Given this list of marker genes Stra6, Hipk2, Hoxa7, Ndst1, Lrp6, Myo3a, Pitx2, Fgf8, Fzd6, Srf, Dll1, Mmp16, Hoxb7, Slc39a3, Atp8a2, Prox1, Hlx, Nckap1, Ovol2, Bloc1s5, Tbx3, Myf5, Shh, Chst11, Triobp, Grhl2, Osr2, Mir96, Wdpcp, Tifab, Mapk3, Col11a1, Kdm2b, Eif4a3l2, Eif4a3l1, Foxf2, Eya1, Sox9, Mthfd1l, Clrn1, Tgfbr2, Tshr, Efemp1 (NCBI Gene Id 216616), Atp6v1b1, Hoxd4, Dscaml1, Irx5, Gli2, Otx2, Setdb2, Tead2, Tcf7l2 (NCBI Gene Id 21416), Nkx2-5, Phactr4, Lrig3, Setd2, Vangl2, Mapk1, Foxn4, Ccdc39, Hoxb4, Aldh1a3, Prkra, Celsr1, Hoxa9, Wnt1, Frs2, Ihh, Fuz, Fzd2, Ush1g, Dvl3, Hoxa11, Myo6, Bmi1, Ccdc40, Hoxb8, Tshz1, Hoxd11, Arid1a, Ppp1r35, Wnt3a, 2610005L07Rik, Foxl2, Ift140, Bcr (NCBI Gene Id 71258), Eng, Epha2, Strc, Th, Col2a1, Kif3a, Tgfbr1, Grxcr2, Noto, Pou4f3 (POU domain, class 4, transcription factor 3), Psen1, Slitrk6, Alx4, Insig2, Gli1 (NCBI Gene Id 22705), Ccdc103, Ttc39c, Hpn, Foxh1, Zic3, Gbx2, Foxg1, Ror2, Cdh23, Hoxd3, Mib1, Grxcr1, Tmie, Ift172, Foxc2, Mfap5, Hand2, Hoxb2, Ift57, Eya4, Hyal1, Scrib (NCBI Gene Id 54559), Atp2b2, Wdr19, Ryr2, Chrna10, Sp1, Pds5a, Hoxa4, Pcdh15, Naglu (NCBI Gene Id 27419), Wnt9a, Gnas, C2cd3, Prrx2, Sox11, Satb2, Spry2, Rbp4, Smad2, Mmp14, Slc39a1, Foxe1, Wnt11, Pcgf2, Rarb, Men1, Ush1c, Myo7a, Kdm2a, Gas1, Ripor2, Tead1, Fgf9, Hoxa1, Sox17, Tcap, Tmed2, Frzb, Axin1, Dlx1as, Lbx1, Gja1, Pou3f4, Nr4a3, Mef2c, Chrna9, Fgfr2, Neurog1, Otx1, Hoxa5, Ift52 (NCBI Gene Id 99173), Aldh1a1, Fgf3, Enpp1, Rest (NCBI Gene Id 72127), Dlx5, Myo3b, Lhfpl5, Fgfr1, Wnt9b, Mdfi, Ednra, Tfap2a, Whrn, Notch2, Nog, Pdzd7, Mycn, Insig1, Hoxc9, Cfc1 (NCBI Gene Id 98634), Dvl1, Hmx3, Gfi1, Dlx6, Pls1, Cthrc1, Cluap1, Sufu, Twist2, Tbx20, Ptprq, Six1, Alx1, Ctnnb1, Bmp4, Mafb, Kdm6a (NCBI Gene Id 22289), Nectin1, Nkx3-2, Rac1, Hoxc4 (NCBI Gene Id 15423), Gata4, Gli3, Dlx2, Edn1, Sobp (NCBI Gene Id 78400), Foxf1, Ptk7, T2, Mical2, Mesp1, Hoxd10, Stox1, Pax8, Nherf1, Wnt5a, Hoxb9 (homeobox B9), Ext1, Hoxa3, Nphp3, Megf8, Rnf207, Myc, Gsc, Neurod1, Kcnq4, Runx2, Rarg, Clic5, Pkd2, Rdh10, Hspg2, Ift122, Hoxb3, Cryaa, T, Yap1, Pdgfra, Lrig1, Asxl2, Smarca4, Tprn, Hoxb5, Grhl3, Fbn2, Sp3, Hand1 (NCBI Gene Id 15110), Abr, Aldh1a2, Gata2, Kcnq1, Ephb2, Tgfb3, Arl13b, Chd7, Hoxb6, Folr1, Otop1, Tbx18, Clrn2, Hesx1, Hipk1, Nectin3, Gjb6, Cep290, Osr1, Fzd3, Six3, Six2, Tbx15, Sparc, Cited2, Ntn1, Hes1, Dnaaf1, Itga8, Sox2, Hoxb1, Tgfb2, Vax2, Aplnr, Notch1, Hnf1b, Tcf7, Nipbl, Stil, Med12, Gata3, Myo15a, Foxi1, Fzd5, Rbpj, Pax2, Tbx2, Slc44a4, Fbn1, Smo, Tcf21, Prrx1, Hif1a, Pax6, Mfap2, Ankrd24, Efna1, Rpl38, Sec24b, Msx1, Dvl2, Six4, Fgf10, Nodal, Smad3, Bmp7, Hmx2, Crb2, Shox2, Hoxa2, Acvr1, Tulp3, Pax5, Eif4a3, Atoh1, Zeb1, Dlg1, Twist1, Asb2, Rbpms2, Zic1, Id2, Hoxc11, Flvcr1, Lhx1, Hoxd9, Alx3, Sod1, Tbx1, Tecta, Dync2i1, here is a description of the gene set: Morphogenesis, during the embryonic phase, of a tissue or tissues that work together to perform a specific function or functions. Morphogenesis is the process in which anatomical structures are generated and organized. Organs are commonly observed as visibly distinct structures, but may also exist as loosely associated clusters of cells that work together to perform a specific function or functions. Mouse Gene Set: GOBP_EMBRYONIC_ORGAN_MORPHOGENESIS studied in species Mus musculus